The following is a description of a gene set: Human Gene Set: GSE22432_PDC_VS_TGFB1_TREATEDCOMMON_DC_PROGENITOR_DN Genes down-regulated in dendritic cells: plasmacytoid versus cultured common progenitors treated by TGFB1 for 4h. Dendritic cells (DCs) in lymphoid tissue comprise conventional DCs (cDCs) and plasmacytoid DCs (pDCs) that develop from common DC progenitors (CDPs). CDPs are Flt3+c-kitintM-CSFR+ and reside in bone marrow. Here we describe a two-step culture system that recapitulates DC development from c-kithiFlt3-/lo multipotent progenitors (MPPs) into CDPs and further into cDC and pDC subsets. MPPs and CDPs are amplified in vitro with Flt3 ligand, stem cell factor, hyper-IL-6 and insulin- like growth factor-1. The four-factor cocktail readily induces self-renewal of MPPs and their progression into CDPs and has no self-renewal activity on CDPs. The amplified CDPs respond to all known DC poietins and generate all lymphoid tissue DCs in vivo and in vitro. Additionally, in vitro CDPs recapitulate the cell surface marker and gene expression profile of in vivo CDPs and possess a DC-primed transcription profile. Transforming growth factor-β1 (TGF-β1) impacts on CDPs and directs their differentiation towards cDCs. Genome-wide gene expression profiling of TGF-β1-induced genes identified transcription factors, such as interferon regulatory factor-4 (IRF-4) and RelB, that are implicated as instructive factors for cDC subset specification. TGF-β1 also induced the transcription factor inhibitor of differentiation/DNA binding 2 (Id2) that suppresses pDC development. Thus, TGF-β1 directs CDP differentiation into cDC by inducing both cDC instructive factors and pDC inhibitory factors. studied in species Homo sapiens from publication Felker P, Seré K, Lin Q, Becker C, Hristov M, Hieronymus T, Zenke M (PMID 20881193), and this is the list of marker genes: TGFBR2, SDHAF2, CCRL2, CPM, CTDSP2, CHCHD10, PPP1R12A, FEM1C, COBLL1, LBR, ITIH5, TMEM31, TAP1, ABI1, YPEL2, ATF3, PIK3CA, GRAMD2B, NHLRC3, BBS2, CLIC1 (NCBI Gene Id 257617), ARAP2, ATF7IP, PLAC8, CASP8, MLXIP, COTL1, ZNF236, CCDC117 (NCBI Gene Id 150275), FLI1, ALDH2, SH3PXD2A, NFAM1, CARNS1, AP2A2, MALT1, PML, MPP1, ITM2B, IFT140, RAB39A, SNX14, PRKACB, CREB3L2, C12orf57, RFX3, UCKL1, TP53INP1, PDE4B, ACAP1, TSPAN13, PRKCG, MAP2K1, ARHGAP18, ABTB1, EEIG1, TTC7A, GOLM1, ITPKB, RCOR3, SLC25A24, FMNL3, TRIM33, RHOQ, TMEM245, CDK2AP2, APPL2, RNF114, AP1S2, HMCES, PPP1R21, SOCS3, SIGIRR, SLC28A2, TRIM21, TRIM24, SESN3, PPP1R3C, ADCK2, CERS4, KLF3, BTK, ZNF18, ABCA3, C19orf12, SASH3 (NCBI Gene Id 93952), COMMD8, LCP2, TRIM56, BNIP3L, RRM2B (NCBI Gene Id 50484), MKNK2, BTG2, FTX, ARHGAP6, STX7, CDKN1B, JMJD1C, LGALS3BP, C11orf68, EZR, IL10RA, STK26, TCIRG1, CD36, PIK3CD, ARHGAP15, TMUB2, MSH3, ARHGAP25, KIDINS220, JAK1, ADAMTS10, PPP3CC, H2AC25, TMEM26, RCHY1, RFLNB (refilin B), DCLK2, MYO18A, MIDEAS, CIITA, CMTM7, ABHD16A, SLC44A2, CHST11, REV3L, GALNT12, TTLL1, IKBKG (NCBI Gene Id 8517), NDST1, OAS2, GAD1, IFIT3, DENND1C, CD82, RAPGEF4, LYST, FRAT2, ARSK (NCBI Gene Id 153642), PTPN6, AGO4, PHC3, CKLF, SRI, GAB3, SMIM14, ING4, ZNF592, SNX29 (sorting nexin 29), RABAC1, ITGB7, TRAF5, EDARADD, PPCDC, PIP4K2A, CCM2, CD40, DUSP5 (dual specificity phosphatase 5), E2F2, PGM2L1, STING1, NEDD9, GPD2, C16orf54, INO80D, OTUB2, PIK3R1, SH3BGRL3, CEP128, IRF7, GNA15, DDIT3, DNAH8 (dynein axonemal heavy chain 8), IFT172 (intraflagellar transport 172), INVS, TOR4A, MYL11, MAPK14, UBLCP1, RELCH, TNK2, TUG1, SLAIN1, LCORL, ZMYND8, UNC119, APOBEC1, CYP4V2, CTSW, CDC42EP3, ULK2, LRRK1, TMEM64, PIGV, TBC1D10C (NCBI Gene Id 374403), CFP, SMC6, FERMT3, TPST2